Given this list of marker genes B4galt2, Usp5, Syngr1, Cpsf2, Phc2, Zfhx3, Dlk2, Arhgap23, Fxr2, AW146154, Klhl18, Psma3 (NCBI Gene Id 19167), Klrk1, Pabpn1, Sema7a, Nrp2, Mtcl2, Lyrm7, Dctn4, Zfp593, Camk2a, Rab37, Socs1 (suppressor of cytokine signaling 1), Tlr4, Avpr1b, Vipas39, Trabd2b, Brdt, Thsd7b, Atp6v0a2, Rnf144b, Tirap, Umps, Txlna, Tspoap1, Mllt10, Nhej1, Ptpn2 (protein tyrosine phosphatase, non-receptor type 2), Med10 (NCBI Gene Id 97867), Mettl27, Wnk2, Zbp1, Cdk5, Ccdc127, Igf2bp1, Camkk2, Metrnl, Ube2g2, Tom1l2, Baiap2, Zfp652, Zbtb2 (zinc finger and BTB domain containing 2), Itga9, Phlpp1, Dnajb2, Furin, St8sia5, Smpd4, Postn, Rsad1, here is a description of the gene set: from publication Chen Y, Wang X (PMID 31504780) species: Mus musculus Genes predicted to be targets of miRBase v22 microRNA mmu_miR_331_3p in miRDB v6.0 with MirTarget v4 prediction scores > 80 (high confidence targets). Mouse Gene Set: MIR_331_3P